Given this list of marker genes H2-M9, Psmb6, Psme1, Psma6, Psme2, H2-Q4, Psmb7, Psma4, Tapbp (NCBI Gene Id 28066), H2-K1, Stx4a, Pdia3, H2-M3, Snap23, H2-Q10, B2m, Psma7, Psme2b, Vamp3, H2-T23, Psmb4, Tap2, H2-M10.6 (NCBI Gene Id 399549), H2-M5, H2-M10.1, H2-M11, H2-Q1 (histocompatibility 2, Q region locus 1), Psmb10 (NCBI Gene Id 19171), Psma1, H2-T22, H2-Q7, Psma3, Sec22b, H2-Q2, H2-M10.2, Psma2, H2-M2, Psmb8, H2-M10.3, Psma5, H2-M1, Psmb3, Vamp8, H2-M10.4, Tap1 (NCBI Gene Id 21354), Calr, H2-Q6, H2-T10, H2-M10.5, here is a description of the gene set: studied in species Mus musculus Mouse Gene Set: REACTOME_ER_PHAGOSOME_PATHWAY ER-Phagosome pathway